The following is a description of a gene set: Abnormality of the distal phalanx of the 5th finger Abnormality of the distal phalanx of the 5th (little) finger. studied in species Homo sapiens Human Gene Set: HP_ABNORMALITY_OF_THE_DISTAL_PHALANX_OF_THE_5TH_FINGER, and this is the list of marker genes: BBS9, BBS7, WDPCP, TTC8, TFAP2B, HNRNPR, BBS10, CEP290, ERI1, IGF2, IFT74, LZTFL1, BBIP1, BBS12, CEP19, IFT172, COL2A1, GJA1, BBS1, ARL6, NPHP1, NPR2, CFAP418, TRIM32, BBS4, MKS1, BBS2, MKKS (NCBI Gene Id 8195), SDCCAG8, IFT27, SMARCB1, ARID1B, BBS5, SCAPER, SCLT1